Given this list of marker genes PMM2, PUS10, RPUSD2, RPUSD4 (NCBI Gene Id 84881), RPUSD3, TRUB1, RPUSD1, MMUT, PGM2, TRUB2, PMM1, PGM1, LSS, PUS1, CYP2J2, PGAM2, PUS7L, BPGM, PGAM1, PUS3, TMEM86B, DKC1, PGAM4, ALOXE3, PGM5, PUSL1, PGM2L1, PUS7, PGM3, here is a description of the gene set: species: Homo sapiens Catalysis of the transfer of a functional group from one position to another within a single molecule. Human Gene Set: GOMF_INTRAMOLECULAR_TRANSFERASE_ACTIVITY